Given this list of marker genes KL, BMP2, WNT5A, LTF (lactotransferrin), P2RX7, CCN1, BMP6, ADCY10, VDR, PKDCC, BMPR1A, OSR2, ACVR2A, RXRA, SLC8A1, ANO6, ALOX5, ADRB2, FZD9, TOB2, WNT10B, PTH, ISG15 (NCBI Gene Id 9636), FAM20C, BMP4 (bone morphogenetic protein 4), TACR1, FBN2, BMPR1B, GPM6B, ACVR2B, BMPR2, TENT5A (NCBI Gene Id 55603), CCN3, TFAP2A, OXT, OSR1, MEF2C, ACVR1, TAC1, PTN, ATRAID, NIPBL (NIPBL cohesin loading factor), SLC20A2, SOX11, SETD2, NELL1, ACTN3, ATP2B1, ZBTB16, WNT4, PTPN11, ADGRV1, RXRB, BMP7, TMEM119, SMAD3 (NCBI Gene Id 51521), here is a description of the gene set: Human Gene Set: GOBP_POSITIVE_REGULATION_OF_OSSIFICATION studied in species Homo sapiens Any process that activates or increases the frequency, rate or extent of ossification, the formation of bone or of a bony substance or the conversion of fibrous tissue or of cartilage into bone or a bony substance.